The following is a description of a gene set: species: Homo sapiens Human Gene Set: GOMF_PHOSPHOPROTEIN_BINDING Binding to a phosphorylated protein., and this is the list of marker genes: SAMSN1, PTPN11, PITX2, GPRIN1, CBLB, ABL1, PIK3R2, MID1, PHF6, LYN, PCIF1, HCK, CBL, SHC1, NCK2, PTPN6, CBX4, RB1, PIN1, TBL2, LCK, PLAT, PIK3R1, MTOR, TRPV1, LEO1, PLCG2, BTRC, GRAP2, YWHAZ, VAV2, SFN, PAFAH1B1, PTPN3, CRKL, FBXW7, SHE, SRC, GRB2, MEN1, IRS1, SH2D3A, STAP1, BCAR3, PRKCSH, VAV1, SOCS3, UBASH3B, FGR, PIK3R3, TBK1, GRAP, PIH1D1, YES1, EPB41, SNCA, CRMP1, NEDD4, PTPN5, URI1, PFN1, MAPK3, YWHAB, RRAGA, THRAP3, YWHAE, CRK, PKD2, BBS1, DPYSL3, DPYS, SHB, MID2, SYK, FKBP4, CBLC, RASA1, MAPK1, SCAF8, APTX, SH2D3C, SLA, ZAP70, SCAF4, LRP11, ARR3, IGF2R, TOX3, SHF, SH3BP2, SAG, LDLRAP1, SHD, SHC3, ABL2